The following is a description of a gene set: studied in species Mus musculus Mouse genes annotated to decreased incidence of induced tumors (MP:0002053) retrieved from the Mouse Genome Informatics database via MouseMine from publication Motenko H, Neuhauser SB, O'Keefe M, Richardson JE (PMID 26092688) Mouse Gene Set: MP_DECREASED_INCIDENCE_OF_INDUCED_TUMORS, and this is the list of marker genes: Zmiz1, Cd151, Klk6, Cyp2c23, Krt10, H2-Ob (NCBI Gene Id 15002), Ct55, Cebpb, Lrig2, Ccng1, Eif2s2, Pgr, Il6, Cdk1, Terc, a, Uqcc3